Given this list of marker genes FGF9, DNMT1, PDGFB, MIR15B, NFATC3, PDCD4, MIR100, MIR221, MIR21, HEY2, MIR26A1, NFATC2, NFATC1, here is a description of the gene set: Human Gene Set: GOBP_NEGATIVE_REGULATION_OF_VASCULAR_ASSOCIATED_SMOOTH_MUSCLE_CELL_DIFFERENTIATION Any process that stops, prevents or reduces the frequency, rate or extent of vascular smooth muscle cell differentiation. studied in species Homo sapiens